Given this list of marker genes EDDM3A, SEMG1, TAC1, OXT, KLK14, ACVR2A, TACR1, P2RX1, SERPINE2, AVPR1A, DDO, here is a description of the gene set: studied in species Homo sapiens Human Gene Set: GOBP_INSEMINATION The introduction of semen or sperm into the genital tract of a female.